The following is a description of a gene set: from publication Konuma T, Nakamura S, Miyagi S, Negishi M, Chiba T, Oguro H, Yuan J, Mochizuki-Kashio M, Ichikawa H, Miyoshi H, Vidal M, Iwama A (PMID 21540074) studied in species Homo sapiens Genes up-regulated in comparison of LSK versus CD4 T cells. Human Gene Set: GSE27786_LSK_VS_CD4_TCELL_UP Each fraction of mouse hematopoietic cells was purified by cell sorting from bone marrow of 8-week-old C57BL/6 mice, and its gene expression was analyzed., and this is the list of marker genes: ZFAND4, RNF168, CPNE3, TOPBP1, RETSAT, IQGAP3, SRSF6, VDAC1, NFAM1 (NFAT activating protein with ITAM motif 1), USP1, TFCP2, BTBD3, MRPL38, ZNF704, RUVBL2, PARP1 (NCBI Gene Id 142), CTXN1, KLHL22, ESR1 (NCBI Gene Id 2099), SNHG7, NARS2, RUFY1 (NCBI Gene Id 80230), ALKBH1, ZNF777, TMEM106C, CHML, CNBP, RNF122, SLC7A1, MLST8, PKD2, NYNRIN (NCBI Gene Id 80151), ATG4C, KCTD15, MESD, DDIAS, GTF2IRD1 (NCBI Gene Id 9569), TIE1, CCNF, BLVRB, MPHOSPH10, NFIC, LPCAT2, TRMT61A, PPHLN1, YTHDF2 (YTH N6-methyladenosine RNA binding protein F2), SAPCD1, GRWD1, MSRA, PCYT1A, NOB1, TUBB6, C11orf54, DYNC2H1, RUSF1, DHX33, MIB1, LRRK2, ZNF839, STAU2, BET1, CSE1L, MTA3, ENOX2, IFTAP, CCL19, BLZF1, NUP133 (NCBI Gene Id 55746), TMEM40, SASS6, CLNS1A, STARD10, RSPH3, NIFK, LRRC8D, CEP83-DT, GINS1 (NCBI Gene Id 9837), TGIF2, PARVG, RNASE6, NR2F2, PLPPR3, ZCCHC24, ZC4H2, PHETA2, DYNC2I2, CFAP68, C8orf82, PPIE, UBFD1 (ubiquitin family domain containing 1), SUV39H2, DPAGT1, TCEAL9, AKAP1, SMAD1, ARMC2, MAP1LC3A, NIPAL2, LAIR1, HLA-DMB, B9D2, FAM229B, ZRANB3, ZFAND2A, MOAP1, GPSM1, MAOA, SHMT1, EIF2B1, RENBP, SLC25A3, VPS50, PIGN, SMIM7, MAGT1, ECI2, GUSB, FADS1, TSGA10, NFS1, SSR3, SLC22A16, NTPCR, TMEM97, BMP1, TYMS, ZNF32, SLC35F5, SARS2, TPD52, GALK1, RPUSD1, ACSL3, CA12, GARRE1, PEX5, LTBR, QTRT2, HSPBP1, NDUFB8, GOLM2, CSNK1E, SEMA4C, KYAT3, SMPD4, MED22, ZSWIM7, FKBP1B, AFG3L2, RLIG1, C6orf132, GUCA1A, PSPC1, ZMYM4, STAM, MMGT1, PDSS2, DTNBP1, NINJ1, ARHGAP23, DHRS3 (dehydrogenase/reductase 3), CSF2RA, FAM135A, ABCE1, PRMT3, PLEKHO1, NKX2-3, LRRC66, ZDHHC13, PDGFA, SANBR, SFXN2, NRARP, IMMP2L, WDR19, ATG10, ZYX, TEFM, FSTL1, ZNF569, FDPS, PGPEP1, PEMT, FCER1G, TLX2, PACRGL, HTRA2, UQCC6, E2F6, HMMR, DHRS4, SLF2, FANCD2, PWWP2B, TUFT1, MRPL15, RHOT1, POLR1E, SNAPIN, PLK1